Given this list of marker genes LAMA3, TSHR, LAMC2, ASAH1, KRT5, KRT14, TSHB, LAMB3, LTBP4, NKX2-5, MEG3, PAX8, FOXE1, RTL1, DLK1, DUOX2, EZH2, NKX2-1, PIGN, SLC26A4, here is a description of the gene set: Human Gene Set: HP_HOARSE_CRY Hoarse cry studied in species Homo sapiens